Given this list of marker genes Stat3, Isg15, Tal1, Fam210b, Kat7, Smap1, Brd1, Stat1, Stat5b, Med1, Nckap1l, Acvr1b, Ets1, Gata2, Ankrd54, Id2, Gata1, Kdm1a, Hspa1b, Glul, Prmt1, Prkdc, Foxo3, Acvr2a, Abcb10, Inpp5d, Hmgb2, Mapk14, Inhba, Hif1a, here is a description of the gene set: Mouse Gene Set: GOBP_POSITIVE_REGULATION_OF_ERYTHROCYTE_DIFFERENTIATION studied in species Mus musculus Any process that activates or increases the frequency, rate or extent of erythrocyte differentiation.